Given this list of marker genes CA4, CA1, SLC4A1, AQP1 (aquaporin 1 (Colton blood group)), HBA1, HBB, RHAG, CA2, here is a description of the gene set: Reactome Pathway: Erythrocytes take up oxygen and release carbon dioxide part of: O2/CO2 exchange in erythrocytes Erythrocytes circulating through the capillaries of the lung must exchange carbon dioxide (CO2) for oxygen (O2) during their short (0.5-1 sec.) transit time in pulmonary tissue (Reviewed in Jensen 2004, Esbaugh and Tufts 2006, Boron 2010). CO2 bound as carbamate to the N-terminus of hemoglobin and protons (H+) bound to histidine residues in hemoglobin are released as hemoglobin (HbA) binds O2. Bicarbonate (HCO3-) present in plasma is taken up by erythrocytes via the band3 anion exchanger (AE1, SLC4A1) and combined with H+ by carbonic anhydrases I and II (CA1/CA2) to yield water and CO2 (Reviewed by Esbaugh and Tufts 2006). CO2 is passively transported out of the erythrocyte by AQP1 and RhAG. HCO3- in plasma is also directly dehydrated by extracellular carbonic anhydrase IV (CA4) present on endothelial cells lining the capillaries in the lung. studied in species Homo sapiens